Given this list of marker genes DYNLT2B, NKX3-2, SMO, TRPV6, IFT172, DYNC2I2, FIG4, DDR2, DYNC2LI1, CEP120, DYNC2I1, RTL1, PAM16, WDR35, INTU, FGFR3, SF3B4, ORC1, VAC14, MEG3, RNU12 (NCBI Gene Id 574043), SCARF2, DYNC2H1, DLK1, PTCH1, CUL7 (cullin 7), EVC, GPC4, LMX1B, NEK1, DHCR24, LBR, GPC3, IFT140, TRIP11, TAPT1, SLC26A2, IFT80, MYF5, FLNA, IFT122, SLC35D1, UBA1, DDRGK1, KIAA0586, EVC2 (EvC ciliary complex subunit 2), COL11A1, COL11A2 (NCBI Gene Id 494120), NSDHL, GNPTAB, SETBP1, GPX4, RUNX2, ALPL, CHD6, PLCB3, ALG12, C2CD3, HSPG2, PORCN, EZH2, IFT43, COL2A1, LAMA5, PTH1R, IFT81, TRPV4, IHH, INPPL1, ORC6, CSPP1, here is a description of the gene set: Reduced rib length. species: Homo sapiens Short ribs Human Gene Set: HP_SHORT_RIBS